The following is a description of a gene set: The directed movement of a lipid from outside of a cell into a cell. This may occur via transport across the plasma membrane or via endocytosis. species: Homo sapiens Human Gene Set: GOBP_LIPID_IMPORT_INTO_CELL, and this is the list of marker genes: ACSL5, THBS1, FABP3, SLC27A2, STRA6, AKT1, CD36, AKT2, PLPPR4, SLC2A1, RPS6KB1, ACSL3, RBP4, IRS2, SLC27A1, SLC27A4, SPX, SLC27A6, LIPA, EPRS1, ACSL1, SLC27A5